The following is a description of a gene set: Reactome Pathway: RAB GEFs exchange GTP for GDP on RABs species: Mus musculus This event has been computationally inferred from an event that has been demonstrated in another species.<p>The inference is based on the homology mapping from PANTHER. Briefly, reactions for which all involved PhysicalEntities (in input, output and catalyst) have a mapped orthologue/paralogue (for complexes at least 75% of components must have a mapping) are inferred to the other species. electronically inferred by orthology from the curated human pathway part of: Rab regulation of trafficking, and this is the list of marker genes: Rabgef1, Rab38, Rab18, Rab8a, Rab1b, Rab32, Ccz1, Dennd6a, Rab39, Dennd6b, Rab5c, Ulk1, Dennd4b, Dennd2b (DENN domain containing 2B), Rab39b, Gdi1, Rab1a, Dennd1c, Mon1a, Dennd5b, Sbf1, Rin1, Rab7, Rab9b, Trappc8 (trafficking protein particle complex 8), Rab6a, Trappc9, Ywhae, Rab27b, Rab3gap2, Rab35, Rab21, Rab3ip, Rab10, Rab3a, Trappc5, Gdi2, Dennd2a, Rab8b